The following is a description of a gene set: studied in species Mus musculus Mouse Gene Set: GOBP_DAMP_METABOLIC_PROCESS The chemical reactions and pathways involving dAMP, deoxyadenosine monophosphate (2'-deoxyadenosine 5'-phosphate)., and this is the list of marker genes: Nt5c1a, Uox, Pnp, Urah, Dck, Adk, Dguok, Xdh, Urad, Ada